Given this list of marker genes SLC9A8, ST3GAL1, RAB38, SNX9, LRRK2, SORT1, TPST1, GRN, FAM91A1, APH1A, PCSK4, HLA-DPA1, GOLGA4, GSAP, RHOBTB3, CLVS1, RAB13, LGR6, YIPF2, VPS54, FURIN, PLD4, MME, AP1M1, GOLGA2, OSBP, ASAP2, ATG9A (autophagy related 9A), SLC2A4, ATL1, RBFOX1, CALN1, VPS53, B4GALNT4, TMEM79, ST6GAL1, ATP9A, TRAPPC4, GOLGA8O, GALNT1, GOLGA8M, GCC2, TPST2, GOLGA3, GGA1, HTR7, GAL3ST2, CA4, MGAT4D, SLC39A9, RELCH, AP1S2, VAMP7, HLA-DQA2, B4GALT2, CANT1 (calcium activated nucleotidase 1), SORL1, SAR1A, ATP8A2, RAB10, RAB9A, RAB43, PCSK7, TJAP1, TMEM165, SLC24A5, STX10, GOLGA8S, PREPL, AKAP9, GALNT2, B4GALT5, SCAMP5, AP1G1, NSG1, GOLGA8IP, CHPF, MS4A7, PLPP3, DNMBP, GAL3ST3 (NCBI Gene Id 89792), WDR11, ARL5C, HLA-DRB1, TBC1D23 (NCBI Gene Id 55773), LPCAT2, ATP2C1, CHST6, MARCHF1, CCDC186, PCSK1N, XYLT1, ATP8A1, GOLGA5, POSTN, COG3, PIK3C2A (phosphatidylinositol-4-phosphate 3-kinase catalytic subunit type 2 alpha), TMBIM4, VAMP5, VAMP3, GAL3ST4, FUT3, INPP5K, COG5, NECAB3, ASAP1, GOLGA6A, NSFL1C, CHAC1, GOLGA8N, NSG2, CLN3, ATP7B, ARFIP2, NAGPA, TEPSIN, BICD1, ECPAS, COG2, RAB27B, COG8, SULF1, AP4E1, SCFD1 (NCBI Gene Id 51681), DPY30, GOLGA8B, RAB7B (NCBI Gene Id 84855), ARFIP1, AP1S1, GBA1, MGAT4A, GOLGA8T, PI4K2B, VTI1A (vesicle transport through interaction with t-SNAREs 1A), ARFGEF1, ATP8B2, MS4A6A, CHID1, RAB34, ZDHHC14 (NCBI Gene Id 79683), ATXN2, DENND5A, GOLGA8DP, SLC30A5, A3GALT2, ARL5B, CSGALNACT1, CLTCL1, HACE1, MBTPS1, SYT17, TOM1L1 (NCBI Gene Id 10040), BCAP31, AFTPH, BAIAP3, GOLT1A, STX8, FCMR, TRAPPC9, PLEKHA3, FUT6, ST3GAL4, CORO7, GOLGA8CP, B4GALNT3 (beta-1,4-N-acetyl-galactosaminyltransferase 3), M6PR, ATG9B, GOLGA8J, B4GALT1, B4GALT3, GOLIM4, BECN1, RAB29, USP6NL, CNST, HLA-DRB3, CRACR2A, TMEM87B, PCSK5, GOLGA8H (golgin A8 family member H), PHETA2, PRKD1, RIC1, PLOD3, GBF1, MARCHF4, ARSL, AZIN2, NDST1, OCRL, GOLGA8R, EIPR1, MS4A6E, SMPD4, CHPF2, BPNT2, SLC9A7, HLA-DRB5, HOOK2, AP1B1, LLGL1, HLA-DPB1, RAB32, CLTB, ARAP1, UXS1, HLA-DQB1, GGA3, HLA-DQB2, INPP5E, RAB31, PITPNM1, ST6GAL2, RAB21, SLC35B2, HID1, GPR89B, LYSET, USO1, LYPLA2, BOK (NCBI Gene Id 84558), LGR5, FUT8, RAB14, SMPD3, FUT5, STX16, ST3GAL2, ATP8B4, ARFRP1, CLIP3, LAMP2, AP1M2, RAB8A, MOB4, GGTA1, CIMAP3, TMEM59 (NCBI Gene Id 9528), GOLGA6B, MICALL1, CLVS2, STX6, YIPF6, MYO18A, GOLGA6D, CSGALNACT2, GOLGA8Q, MARCHF9, HLA-DRB4, TMEM230, PSENEN, ACP3, CLTA, CHST5, NBEA, CHST2, B4GALT7, TGOLN2, VRK1, ATP9B, SULF2, VCPIP1, RGS20, SCAMP1, SCOC, CLASP2, ATP2C2, PHETA1 (NCBI Gene Id 144717), APP, CLTC, COG7, KIF13A, SYT11, GOLGA8A, RAB11A, CLBA1, TRAPPC6A, B4GALT6, MLANA, GOLGA7, KIAA0319L, CD74, SGMS1, MAN2A1, VPS13B, GCNT1, SNAP25, COG4, TRAPPC6B (trafficking protein particle complex subunit 6B), SLC66A2, LAP3, OPTN, COG6, TMED3, YIPF1 (NCBI Gene Id 54489), PLEKHA8, CBY1, RABEPK (NCBI Gene Id 10244), C17orf75, WLS, ATP7A, AP4M1, CD2AP, KLHL20 (NCBI Gene Id 27252), SAR1B, WIPI1, PI4K2A, FUT7, BACE2, FUT9, CHST4, ST3GAL3, ARFGEF2, GPR89A, CHSY3, YIPF5, ATP8B1 (NCBI Gene Id 5205), COG1, NSF, GALNT3, GNAS, AP4S1 (adaptor related protein complex 4 subunit sigma 1), RAC1, VAMP2, MGAT2, IGF2R (NCBI Gene Id 3482), GCC1, YIPF4, PICK1, ATP8B3, YIPF7, ZFYVE1, GOSR1 (NCBI Gene Id 9527), TMEM87A, GOLGA8K, AP4B1, SLC30A7, DOP1A, ARL5A, DNAAF6, GOLPH3L, VPS51, GOLGA1, PLK3, FUT2, HLA-A, RGP1, RAB30, RAB6A, VPS52, VAMP4, GGA2, CABP7, SCAMP2, GPER1 (NCBI Gene Id 2852), FUT1, TGFBI, TMEM115, CCDC91, CHSY1, SCAMP4, GOLGA6C, SYS1, RASIP1, AP1S3, RAB11FIP3, BIRC6, ARL1, TMED2, MMP24, HLA-DQA1, MYO1B, GOLPH3, ABO, SLC30A6, FUT4, NMNAT2, HLA-DRA, DOP1B, BACE1, BET1L, TAS2R16, SCAMP3 (secretory carrier membrane protein 3), PLEKHJ1, PHAF1, GPR108, ELAPOR1, SLC11A2, CDH1, GOLGB1, B3GALT6, MGAT4B, STX4, here is a description of the gene set: A compartment that consists of a lumen and an enclosing membrane, and is part of the Golgi apparatus. Human Gene Set: GOCC_GOLGI_APPARATUS_SUBCOMPARTMENT studied in species Homo sapiens